The following is a description of a gene set: Mouse Gene Set: MIR_9768_5P species: Mus musculus Genes predicted to be targets of miRBase v22 microRNA mmu_miR_9768_5p in miRDB v6.0 with MirTarget v4 prediction scores > 80 (high confidence targets). from publication Chen Y, Wang X (PMID 31504780), and this is the list of marker genes: Skap2, Kcnh8, Gga2, Mtmr6, Zcchc3, Wfdc5, Togaram1 (TOG array regulator of axonemal microtubules 1), Vamp3, Xrcc5, Deptor, Dars1, Mcrip2, Hoxd3, Zscan20 (zinc finger and SCAN domains 20), Aak1 (AP2 associated kinase 1), Oxct1, Gjd2, Hadha, Jazf1, Hyou1, Ppm1e, Unc13c, Ube2b, Plpp5 (phospholipid phosphatase 5), Raver1, Plppr4, Gstm1, Psen2, Mal2, Rfx5, Pmepa1, H2-M10.5, Pex7, Ash2l, Inhbb, Gad1, Nfatc3, Kdm2a, Mfsd4a, Shox2, Jakmip3, Bcl11a, Gnao1, Naa50, Gstm3, Ube2q2, Frem2, Hecw2, Mecp2, Farp1, Rnf138, Dlst, Tmed7, Gsk3b, Kras, Lrig1, Lair1, Foxo1, Axin1, Elovl5, Ntn4, Ankrd44, Srgap2, Nr4a3, Wasf3, Slc39a1, Rgs2, Baz1b, Alg9, Rfx3, Pdcd4, Prkci, Mapk8ip1, Jph2, Arf1, Ptpn12, Gcm2, Vat1l, Ap1m2, Mbnl1, Lrrc7, Gria2, Samd12, Homer1, Cdc42bpb, Hdac11, Rabgap1, Slc22a5, Pim3, Gmcl1, Csmd3, Gria4, Yeats2, Chmp2b, Scgb2b2, Cobl, Jmjd1c, Zfyve26, Esr2, Ezr, Xkr4, H2-M10.3, Smurf2, Rab35, Pim1, Rsf1, Abraxas2, Tut4, Ppm1f, Tent5c, Clvs2, Tmsb4x